Given this list of marker genes LY96 (lymphocyte antigen 96), HLA-DQB1, C1QB (complement C1q B chain), IGKC, ITGAM, HSPA6, C1S, CSF1R, S100A6, IL4R, MRC1, TRBC2, MS4A4A, GZMK, HLA-DRB4, SERPINA1, HLA-DRA, IGKV1D-39, LYZ, ITGBL1, IGHA1, ISG20, CCL2, FCGR3A, TMEM176B, GPNMB, SLC15A3, AIF1, FCGR2B, DOCK2, APOL1, FCGR1A, IFI44L, FCGR2A, FAP, SERPINE1, CXCL10, TNFAIP6 (TNF alpha induced protein 6), ECM1, CFH, CCL5, CCL13, NCKAP1L, CTSC, FHL2, THBS2, NNMT, CXCL9, GABBR1, LUM, CD163, SIGLEC1, ARHGAP15, THBS1, GZMA, HLA-DPA1, CD14, EFEMP1, DCN, CCN5, MME, NCF4, KYNU, C1QA, CD52, SLA, HLA-DQA1, IGLC2, CD44, S100A4, TRAC, C3, SLAMF8, LILRB1, TIMP1, SRPX2, BIN2, CFB, F13A1, IFI30, PLTP, IGHG1, VSIG4, here is a description of the gene set: Top 100 probe sets contrubuting to the positive side of the 1st principal component; predominantly associated with spindle cell and pleomorphic sarcoma samples. species: Homo sapiens In soft tissue sarcomas, the diagnosis of malignant fibrous histiocytoma (MFH) has been a very controversial issue, and MFH is now considered to be reclassified into pleomorphic subtypes of other sarcomas. To characterize MFH genetically, we used an oligonucleotide microarray to analyze gene expression in 105 samples from 10 types of soft tissue tumors. Spindle cell and pleomorphic sarcomas, such as dedifferentiated liposarcoma, myxofibrosarcoma, leiomyosarcoma, malignant peripheral nerve sheath tumor (MPNST), fibrosarcoma and MFH, showed similar gene expression patterns compared to other tumors. Samples from those five sarcoma types could be classified into respective clusters based on gene expression by excluding MFH samples. We calculated distances between MFH samples and other five sarcoma types (dedifferentiated liposarcoma, myxofibrosarcoma, leiomyosarcoma, MPNST and fibrosarcoma) based on differentially expressed genes and evaluated similarities. Three of the 21 MFH samples showed marked similarities to one of the five sarcoma types, which were supported by histological findings. Although most of the remaining 18 MFH samples showed little or no histological resemblance to one of the five sarcoma types, 12 of them showed moderate similarities in terms of gene expression. These results explain the heterogeneity of MFH and show that the majority of MFHs could be reclassified into pleomorphic subtypes of other sarcomas. Taken together, gene expression profiling could be a useful tool to unveil the difference in the underlying molecular backgrounds, which leads to a rational taxonomy and diagnosis of a diverse group of soft tissue sarcomas. from publication Nakayama R, Nemoto T, Takahashi H, Ohta T, Kawai A, Seki K, Yoshida T, Toyama Y, Ichikawa H, Hasegawa T (PMID 17464315) Human Gene Set: NAKAYAMA_SOFT_TISSUE_TUMORS_PCA1_UP